The following is a description of a gene set: Human Gene Set: HP_ABNORMAL_ENERGY_EXPENDITURE Any anomaly in the utilization of energy (calories). Abnormal energy expenditure species: Homo sapiens, and this is the list of marker genes: SIM1, UCP3, PPARG, AGRP, GHRL, ENPP1, NR0B2, POMC, CARTPT, ADRB3, SDC3, NGLY1